Given this list of marker genes HOXA9, ZIC1, LMO3, ARL4C, PRRX1, RELCH, HOXB8, KLF5, ELK3, ZNF654, EIF5A, MMP14, POGZ, ZFAND6 (zinc finger AN1-type containing 6), LINC03122, ITGBL1, FAM13B, HOXA4, SFN, PLEKHA6, LRRTM1, MBNL2 (NCBI Gene Id 55479), CDC14A, DCDC1, CACNB3, ZNF219, AMD1, SAV1, RCAN2, CACNA1S, FGF3, ITIH6, EOMES (NCBI Gene Id 8320), DNAJA2, KRT34, ASB4, CDX2, KCNJ8, HNF1A, APEX2, CNN3, SOX5, TUT1, NSD3, WT1-AS, ATP2B4, PER1, SSH2 (slingshot protein phosphatase 2), FAM135B, ZBTB18, MON1A, RHBDL3, RSRC1, RFX4, MITF, POU2F1, ACTR3, HIVEP3, FSIP2, NR2F1, TBC1D21, RP1L1, ZFP36L1, FGF19, NTRK2, MEF2C, ALK, AP1S2, KRT28, CARF, DLX1 (distal-less homeobox 1), GCK, MYH2, GREM1, DPP10, M6PR, BMPR1B, A1CF, LUC7L3, CAMK2D, BMP5, GPR150, CPEB4, SLC9A5, NXF1, NDFIP1, CAP1, SPAG9, CTNNB1, EMCN, HOXC6, ALPK2, THRA, BOC, GRK2, HMGA2, COL10A1, KRT25, CRH, TUBB4A, TMEM81, PIM1, MED24, TFAP2B, MYF5, MAP3K2, WDPCP, NPAS2, SP7, ZIC4, STAC2 (NCBI Gene Id 342667), PDZRN4, ROBO3, RPA3, MAMDC2, RFX5, STC1, ERG, NEK7, RWDD3, COMMD10, PPM1E, MTFR1L, TECTA, ARFGAP2, LRRTM3, COL17A1, BLTP3A, ATP2A3, ZNF827, DES, YPEL4, RPAP2, HHATL, DICER1, IL1RAPL1, LMO1, CORO6, SESN2, ADAMTS17, BAMBI, MYBPC2, SLC26A7, TFAP2D, FLI1, SHOX2, DLG2, TOB1, PART1, HOXD4, SHANK1, ZFP36L2, CEP95, PHC2, ZHX1 (zinc fingers and homeoboxes 1), GPX1, SDE2, CCND1, TNFSF18, ARHGEF7, ATL3, H2AX (H2A.X variant histone), BBOX1, PRKAB1, ANKRD1, CREB5, STOML2, MYH4, FBXO40, GPR157, MMP12, GABARAPL2, PPARGC1A, C8A (complement C8 alpha chain), PIK3R1, PNOC, CMTM4, CLDN14, GPC3, FRA10AC1, TTLL6, HOXB7, FAM91A1, KRT73, RTL9, GLMN, MAP2, NRP1, NKX2-1, JADE1, CHST9, HOXC5, FOXN3, DUSP6, KDM4D, PABIR1, PALS1, MIR9-1HG, SMOC1, CSNK1A1L, C1orf116, RBM4, PCDH9, EPHB2, LTBP1, UBASH3B, HDAC4, TSHZ3, PTPN22 (protein tyrosine phosphatase non-receptor type 22), BMP4, CGN, SYNE2, RIPK4, FMO5, SYNCRIP, PHOX2B, LINC00472, PAK3, JPT2, RNF43, DMD, ARID1A, CHMP1B (NCBI Gene Id 57132), DENND2B, APOE, EDN2, OTX2, SLITRK1, EIF4G2, RBMS3, CADM1, CYLD, SLC37A4, GRIA1, SNX15, RBFOX1, NSD1, BDNF, PGAP1, DNAJB4, CHST8, TNNC1, CXCR5 (C-X-C motif chemokine receptor 5), STAG2, PITX2, FOXP2, HOXC4, NUP54, CYBB, TMEM31, MYO18B, ADCYAP1, ELMO2, FAP, FHOD1, NUP210L, DSG4, ARHGEF2, EFNB3, MAP7D2, UBE2E4P, FEZF2, GAL3ST3, MYH8, PBXIP1, DDX5, NEO1, CS, LRRC39, ETV6, RPP25, CWC15, here is a description of the gene set: Human Gene Set: HOXA4_Q2 Genes having at least one occurrence of the motif AWAATTRG in the regions spanning 4 kb centered on their transcription starting sites. This matches the HOXA4 transcription factor binding site V$HOXA4_Q2 (v7.4 TRANSFAC). species: Homo sapiens